The following is a description of a gene set: Any process that stops, prevents or reduces the frequency, rate or extent of cellular senescence. Mouse Gene Set: GOBP_NEGATIVE_REGULATION_OF_CELLULAR_SENESCENCE studied in species Mus musculus, and this is the list of marker genes: Fzr1, Twist1, Fbxo5, Bcl6, Nampt, Hmga2, Trp63, Plk2, Prkdc, Cdk6, Ybx1, Sirt6, Akt3, Zkscan3, Tbx2, Rbl1, Wnt1, Sirt1, Tert, Terf2, Bcl2l12, Mif, Ang (NCBI Gene Id 11727), Map3k3, Abl1, Gch1, Pten